The following is a description of a gene set: Catalysis of the breakage of a carbon-oxygen bond. Mouse Gene Set: GOMF_CARBON_OXYGEN_LYASE_ACTIVITY species: Mus musculus, and this is the list of marker genes: Polb, Hadha, Xrcc5, Cdyl, Cyp1a1, Hmbs, Pcbd1, Xrcc6 (X-ray repair complementing defective repair in Chinese hamster cells 6), Aco2, Polg, Park7, Car12, Car6, Car2, Car14, Pts, Polq (polymerase (DNA directed), theta), Car15, Alkbh1, Gmds, Hmga1b, Cbs, Pcbd2, Alad, Ptgis, Hacd2, Tpi1 (triosephosphate isomerase 1), Car10, Ireb2, L3hypdh, Car3, Car5b, Hacd1, Etnppl, Car9, Echdc3, Fh1, Uroc1, Nthl1, Hacd4, Thnsl2, Echs1, Hsd17b4, Cyp1b1, Cyp1a2, Car8, Car13, Car11, Car5a, Eno3, Hmga1, Eno1, Apip (NCBI Gene Id 56369), Uros, Car1, Aco1, Fasn, Naxd, Hacd3, Car4, Neil1, Neil3, Hmga2, Eno2, Poll, Tgds, Tbxas1, Car7, Dglucy, Neil2, Eno1b, Cyp2s1, Gatd1, Eno4, Ogg1, Auh, Aloxe3, Ehhadh, Rps3